Given this list of marker genes IRAK1, HSP90AA1, ATM, HSP90AB4P, YWHAE, ATR, TRPV1, EIF2S1, ZFAND1, HSP90AB2P, EP300, THBS1, SUMO1, MAPT, IER5, RBBP7, TCIM, VCP, CREBBP, DNAJC2, HSP90AB1, PDCD6, GSK3B, DNAJB1, HTRA2, STAC, CETN1, STUB1, HSPA1A (NCBI Gene Id 3303), SCARA5, EEF1D (NCBI Gene Id 87167), HDAC2, CLPB, DAXX, LYN, TRPV4, HSP90AB3P, BAG3, FGF1, TFEC, TPR, ST8SIA1, TRPA1, HSBP1, HSPA6, HSP90AA2P, SLC52A3, HSPA1B, DNAJC7, NF1, HMOX1, ATXN3, HDAC6, CXCL10, HSBP1L1, DNAJB6, SIRT1, HIKESHI, HSF1, PRKACA, DHX36, MTOR, SLU7, MAPKAPK2, IL1A, CHORDC1, ANO1, here is a description of the gene set: studied in species Homo sapiens Any process that results in a change in state or activity of a cell (in terms of movement, secretion, enzyme production, gene expression, etc.) as a result of a heat stimulus, a temperature stimulus above the optimal temperature for that organism. Human Gene Set: GOBP_CELLULAR_RESPONSE_TO_HEAT